The following is a description of a gene set: The progression of the dorsal aorta over time, from its initial formation to the mature structure. The dorsal aorta is a blood vessel in a single-pass circulatory system that carries oxygenated blood from the gills to the rest of the body. In a single-pass circulatory system blood passes once through the heart to supply the body once. Mouse Gene Set: GOBP_DORSAL_AORTA_DEVELOPMENT studied in species Mus musculus, and this is the list of marker genes: Ngfr, Acvrl1, Hey1, Bmpr1a, Hey2, Dll4, Nkx3-1, Eng, Rbpj, Srf